Given this list of marker genes ADA2, RPS29, SEPTIN9, FHL1, RPL9, TBX3, RPL26, PTPN11, NPR2, RPL35A, SYNE2, MEOX1, RPS27, EFNB1, PTCH1, RPS7, RPL5, RPL31, TMEM43, GDF6, HSPG2, RPL18, RPL15, RAF1, RPL11, RPS17 (NCBI Gene Id 6218), WBP11, EMD, PAX3 (paired box 3), RPL8, SF3B4, HEATR3, RPL35, TSR2, BRAF, TBX5 (NCBI Gene Id 6910), MAP3K7, RPL27, FLNA, RPS26, SYNE1, LMNA, RPS15A, COL3A1, RPS28, TBX2, RPS19, GDF3, CDH2, RPS24, GATA1, RPS20, RPS10, TMCO1, here is a description of the gene set: Human Gene Set: HP_SPRENGEL_ANOMALY Sprengel anomaly species: Homo sapiens A congenital skeletal deformity characterized by the elevation of one scapula (thus, one scapula is located superior to the other).